Given this list of marker genes CALR3, MESD, AHSA1, HSP90AA5P, APLF, GAK, LYRM7, PDILT, SDHAF4, CDC123, RIC8A, HSPA4, WDR83OS, CLPX, CCT8L2, HSP90B2P, CCT4, HSPA5, HSPA4L, TOR1A, ZPR1, DNAJB6 (DnaJ heat shock protein family (Hsp40) member B6), HSPA1B, DNAJB1, HSP90AB4P, HSPE1, CCT6A, HSPB6, HSP90AA4P, FKBP8, CCT2, DNAJB7, HSP90B1, CCT8, HSP90AB3P, CD74, ANP32E, CCT8L1P, PFDN1, PFDN2, PDCL3, HYOU1, TSC1, HSP90AA2P, DFFA, HSPA1A, HSPA8, HSP90AB2P, TCP1, ZMYND10, HSPA14, HSPA2 (heat shock protein family A (Hsp70) member 2), TAPBP, CCDC47 (NCBI Gene Id 57003), CCT7, TRAP1, HSPA13, RIC3 (NCBI Gene Id 79608), KHSRP, HSPA6, CCT6B, HSPB1, DNAJB8, HSPA1L, HSP90AB1, CCT3, HSPA9, CALR, HYPK, HSPH1, HSP90AA1, CCT5, CLGN, HSPD1, WIPF1, HSPA7, RIC8B, DNLZ, here is a description of the gene set: Human Gene Set: GOMF_PROTEIN_FOLDING_CHAPERONE Binding to a protein or a protein-containing complex to assist the protein folding process. studied in species Homo sapiens